The following is a description of a gene set: studied in species Homo sapiens Human Gene Set: GOBP_INTESTINAL_ABSORPTION A process in which nutrients are taken up from the contents of the intestine., and this is the list of marker genes: SLC2A5, VDR, CLDN15, NPC1, AKR1C1 (NCBI Gene Id 9418), KCNQ1, EPB41, ABCG8, MOGAT2, VIL1, LIMA1, EZR, FABP2, CLDN2, F11R, SLC46A1, LPCAT3, APOA1, HAMP (NCBI Gene Id 57817), LDLR, CYP8B1, TJP2, ABCG5, IREB2, SCARB1, ACO1, PNLIP, CD36, LEP, SOAT2, APOA4, ENPP7, HEPH, APOA2, CEL, NPC1L1, PLS1, ADRA2A, SLC5A1, GCNT3, ABCB1, SLC26A6, UGCG, PRAP1